The following is a description of a gene set: Genes predicted to be targets of miRBase v22 microRNA hsa-miR-4309 in miRDB v6.0 with MirTarget v4 prediction scores > 80 (high confidence targets). studied in species Homo sapiens from publication Chen Y, Wang X (PMID 31504780) Human Gene Set: MIR4309, and this is the list of marker genes: ADAR, EEF2KMT, KLHL9, ZIC1, PFKP, FAM86B2, TMEM245, AKIRIN1, C15orf40, KCNE5, IGDCC3, ORC3, DYRK2, TCIM, EPB41L4B, ZNF793, SERPINB13, FAM86C1P, EFNA5, MAP3K20, GATA4, MED7, SMAP1, BHMT2, TUBB4A, KAZALD1, FAM86B1, EMC8, MEPCE, HOXA5, ONECUT2, KDM5B, VCAN, PRR15, SLC6A4, LRPAP1, TNFRSF11B, INO80D, KDM5C, PATE1, ZNRF3, ADAM10, DENND4A, HMG20A, GCC1, LRR1, CAMK4